Given this list of marker genes ITM2B, ERBB3, NFXL1, CYFIP1, TGIF1, SYTL2, NFYB, KDM2B, ACOT11, OSTM1, TRIM59, ADPRH (NCBI Gene Id 141), BCL2L1, PRDX4, RNF216 (ring finger protein 216), ATP10D, TMEM64, AVEN, AS3MT, SAV1, CD38, SMPDL3A, GPLD1, DONSON, FCRL1, ANP32E, SPATA13, BCL2A1, ELK3, CCNG2, IL10RA (interleukin 10 receptor subunit alpha), ADSS2 (adenylosuccinate synthase 2), SLC35A3, SLC45A4, TMEM65, GABPB1, GPR25, CD99L2, TPST1, FAM120C, MYO1C, NEK7, RNF43, CYB5A, GADD45B, PLA2G4F, CYTH3, TSPAN32, MANSC1, CREBL2, CDC25B, NUDT7, KRT7, KIF5C, SNX14, CD200, PTPRJ, ZNF608, ACOT9 (NCBI Gene Id 23597), ZNF260, ZNF23, UBE2R2, RMND5A, SELENOM, RAPGEF5, IKBIP, METAP2, PLCL1, PPM1B, APLP1, VSIG10, TNIP1, ZNF862, MATK, GLRX, TBC1D14, PPP2R1A (NCBI Gene Id 5518), IL18, CD81, CD274, MAP2K3, ST3GAL2, HOPX, RAB8B (NCBI Gene Id 51762), ATRNL1, CHD9, DCLRE1A, FHIP1A, SEC23A (NCBI Gene Id 353367), EGLN3, SC5D, SLA, BCL3, ENSG00000286190, RELB, ARL6, GPR160, AGFG1, CCR4, IFNAR1, WNK1, CRIP1, GEM, MMD, HNRNPLL, XBP1, CPM, MRPS6, CERK, DNAJA4, AKAP7 (A-kinase anchoring protein 7), LHFPL6, FAR1, PNP, GNPDA1, ERGIC1, COBLL1 (NCBI Gene Id 22837), JAZF1, DNAI4, H2AZ1, FAH (NCBI Gene Id 2184), LTB, CDKN2C, ZDHHC2, XXYLT1, NDST1, VAMP5, CNPY2, DAB2IP, PTPRF, SSR1, MAPK12, TNFSF11, TWSG1, TCEAL9, ARHGAP21, GBP7, SLC4A7, LNX2, PON3, KLF9, ATP5IF1, TMEM170B, OAZ2, LONRF1, HLA-DOA, FAM118A, HOMER1, ABCC3, SLMAP, ZNF839, HACD3, PENK, ANXA4, PHACTR2 (phosphatase and actin regulator 2), FNTA, HIF1A, MIER1, DROSHA, CC2D2A, SNAI2, CNKSR3, NAMPT, SMAP1, LRBA, EEF2K, CYP4V2, CELSR1, MAN2A1, GRHL1, IL10, HSPB1, HIPK2 (NCBI Gene Id 653052), LPIN2, CD44, DCAF17, MBNL3, TKTL1, ADAM17, MYO1F, HEPACAM2, SLBP, MAGEE1, PIM1, ALAD, CAMK2D, RIN2, SH2D1A, RECK, RALGDS, AHCYL2, SESN1 (sestrin 1), STAT5A, IFNGR1, STON1, SSH1, MXD1, FABP5, C6orf89, CD48, here is a description of the gene set: The transcription factor FoxP3 partakes dominantly in the specification and function of FoxP3+ CD4+ T regulatory cells (Tregs), but is neither strictly necessary nor sufficient to determine the characteristic Treg transcriptional signature. Computational network inference and experimental testing assessed the contribution of several other transcription factors (TFs). Enforced expression of Helios or Xbp1 elicited specific signatures, but Eos, Irf4, Satb1, Lef1 and Gata1 elicited exactly the same outcome, synergizing with FoxP3 to activate most of the Treg signature, including key TFs, and enhancing FoxP3 occupancy at its genomic targets. Conversely, the Treg signature was robust to inactivation of any single cofactor. A redundant genetic switch thus locks-in the Treg phenotype, a model which accounts for several aspects of Treg physiology, differentiation and stability. from publication Fu W, Ergun A, Lu T, Hill JA, Haxhinasto S, Fassett MS, Gazit R, Adoro S, Glimcher L, Chan S, Kastner P, Rossi D, Collins JJ, Mathis D, Benoist C (PMID 22961053) Human Gene Set: GSE40274_LEF1_VS_FOXP3_AND_LEF1_TRANSDUCED_ACTIVATED_CD4_TCELL_UP species: Homo sapiens Genes up-regulated in CD4 T conv over-expressing LEF1 versus LEF1 and FOX3P.